The following is a description of a gene set: Human Gene Set: REACTOME_METABOLISM_OF_ANGIOTENSINOGEN_TO_ANGIOTENSINS studied in species Homo sapiens Metabolism of Angiotensinogen to Angiotensins, and this is the list of marker genes: CPA3, ANPEP (NCBI Gene Id 290), ATP6AP2, GZMH, CTSG, CTSZ, CMA1, ACE, CPB2, CPB1, REN, ACE2, CTSD, MME, ENPEP, AGT, CES1